Given this list of marker genes Ikbip, Acsl4, Zfp1006, Sh2b3, Klhl9, Ddx3y, Tsc1, Pja1, Cd164, Lin28b, Rhoq, Cbln3, Tiam2, Sult1c2, Traf3, Cdc42se2, Crk, Etfbkmt, Camk1d, Raph1, Ptprt, Lmo7, Armc1, Nav1, Gpr183, Sytl5, Hey1, Erbb4, Syap1, Pon1, Abracl, Stam, Mprip, Rap2b, Glrx2, Wnt3, Asb3, Dnajb11, Igf1r, Mroh6, Fam107b, Krtap19-9b, Sdc2, Gabra1, Serpinb10, Hif1a, Nin, Fubp1, Fbxo11 (NCBI Gene Id 98072), Proz, Cd84 (CD84 antigen), Ube2g1, Nxph2, Wnt5a, here is a description of the gene set: from publication Chen Y, Wang X (PMID 31504780) Mouse Gene Set: MIR_6901_3P Genes predicted to be targets of miRBase v22 microRNA mmu_miR_6901_3p in miRDB v6.0 with MirTarget v4 prediction scores > 80 (high confidence targets). studied in species Mus musculus